Given this list of marker genes TLR6, TLR1, NOD2, NOD1, HLA-A, CD1D, TLR2, NAIP, NLRC4, PGLYRP1, PGLYRP4, HLA-DRB1, PGLYRP2, HLA-B, PGLYRP3, SSC5D, here is a description of the gene set: The series of events in which a stimulus from a bacterium is received and converted into a molecular signal. species: Homo sapiens Human Gene Set: GOBP_DETECTION_OF_BACTERIUM